Given this list of marker genes Alox5, Pkp2, Adra1a, Dsc2, Dock5, Akt1, Atp2a1, F2r, Kcne4, Nkx2-5, Asic2, Tnf, Map2k1, Irx5, Jup, Gnao1, Adm2, Hcn4, Mmp2, Slc9a1 (NCBI Gene Id 20544), Fgb, Glp1r (glucagon-like peptide 1 receptor), Egfr, Nup155, Tnni3k, Cav1, Glrx3, Oxt, Kcne3, Casq2, P2rx1 (purinergic receptor P2X, ligand-gated ion channel, 1), Pmch, Oxtr, Ptger3, Kcnip2, Dusp5, Tgfb2, Hey2, Hrc, Sri, Smtnl1, Shox2, Tacr1, Dlg1 (NCBI Gene Id 320792), Ank2, Arhgap42, Cysltr1, Nos3, Dbh, Dsp, Kcnn2, Atp1a2, Casr, Edn3, Popdc2 (NCBI Gene Id 64082), Npy1r, Myl4, Slc4a3, Mtnr1b, Kcna5, Cacnb2, Strit1, Ahr, Pde5a, Nos1, Itga4, Akap6, Avp, Rnf207, Kcnip1, Hdac4, Ptpn1, Prkca, Cacna1e, Ada, Wdr35, Gsk3a, Calm1, Fgf13, Kcne1, Flna, Gjc1, Apela, Ccn2, Gja5, Zdhhc21, Tmem161b, Kcnd2, Scn10a, Apln, Atp5pf, Myh7b, Tnni3, Scn3b, Src, Tac1, Trpv1 (NCBI Gene Id 22366), Tbxas1, Ace, Cx3cl1, Hopx, Drd2, Calm2, Bin1, Scn2b, Kcnj2, Cd38, Rbfox2, Dsg2, Avpr2, Epas1, Stc1, Hmgcr, Scn1b, Htr7, Per2, Adra1b, Thra, Cav3, Kcnh2, Scn4b, Adm, Isl1, Atp1a1, Gch1, Sptbn4, P2rx4, Atp2b4, Smad7, Rhoa, Irx3, Thrb, Kcnj5, Zmpste24, Pebp1, Faah, Tbx2, Cacna2d1, Chga (chromogranin A), Ptger2, Kcne5, Myh7, Trpa1, Mdm2, Agtr1a, Atp2a2, Snta1, Gnai3, Dmd, Gata4, Cacna1g, Grk2, Spx, Bmpr2, Ryr2 (ryanodine receptor 2, cardiac), Add3, Itga9, Atp1b1, Uts2, Kcnq1, Nos1ap, Ace2, Hsp90aa1, Dmpk, Adra2c, Trpm4, Smtn, Stub1, Cacna1b, Icam1, Ager, Adra2a, Scn5a, Ucn (NCBI Gene Id 22226), Ptgs2, Sp4, Crhr2, Chrm2, Tnnt2, Chrna7, Cacna1h, Npff, Zc3h12a, Fgg, Tmem38a, Cacna1c, Chrm3, Calm3 (calmodulin 3), Tbx18, Abl1, Edn1, Tbx5, Tmem65, Smad6, Sumo1, Shc1, Abcc9, Ednra, Tbxa2r, Htr2a, Mir208a, Slc1a1, Ghrl, Cacna1d, Rgs4, Pde4d, Edn2, Atp2b1, Gjd3, Mgll, Agt, Htr1a, Adra1d, Adrb1, Tacr3, Bves, Mdm4, Kcne2, Dock4 (NCBI Gene Id 70756), Hrh2 (NCBI Gene Id 15466), Agtr1b, Sirt1 (NCBI Gene Id 93759), App, Srebf1, Mc3r, Kcnj8, Hbegf, Ctnna3, Adrb2, Slc8a1 (NCBI Gene Id 319418), Myl3, Itgb1, Hif1a, Ffar3, Uts2r (urotensin 2 receptor), Tpm1, Akap9, Pdgfb, Adra2b, Lep, Foxn4, Kcnh6, Csrp3, Rnls, Gpd1l (glycerol-3-phosphate dehydrogenase 1-like), Mybpc3, Drd1, Tmem38b, Myl2, Kcnd3, Pik3r1 (NCBI Gene Id 328326), Gja1, Avpr1b (NCBI Gene Id 26361), Agtr2, Hrh1, Sema3a, Cxadr, Adora1, Mef2a, Adcy10, Fga, Rgs2, Ednrb, Myh6, Ehd3, Rangrf, Ifng, Nppa, Pln, Nmu, Fxyd1, Gnai2, Avpr1a, Agrn, Ptgs1, Fkbp1b, S100a1, Svep1, Bmp10, Th, Htr2c, Gaa, here is a description of the gene set: species: Mus musculus Any process that modulates the frequency, rate or extent of blood circulation. Mouse Gene Set: GOBP_REGULATION_OF_BLOOD_CIRCULATION